Given this list of marker genes PITRM1, CSRP2, APOBEC3B, MICB, KRT20 (keratin 20), SEC61A2, SOCS7, MPZL1, OPTN, MAFB, SH2B3, CAVIN1, F11R (NCBI Gene Id 50848), FHL1, PMEPA1, REPS2, SERPINI1, KDELR3, CLGN, JUN, LIFR, IFFO1, PLAC1, NRGN, SSX3, ZNF571, JPT1, TIMP2, MAGEB2, MKLN1, CDKN1A, AAMDC, PIK3CD, CTSV, ZMIZ2, ATP6V1D, MAP1LC3B, SYNJ2, CDKN2D, ZNF79, TMEM158, FLNC, OXTR, SPTLC2, SLC6A8, STAT3, ODC1, MAP2K3, HSPA2, ENO2, ATF3 (activating transcription factor 3), PLK3, CDR2L, GLS (NCBI Gene Id 51679), DUSP14, TRIO, ZNF331, H2BC8, TSC22D2, ITCH, C3orf52, FERMT2, KCNV2, TUBB2A, ATP6V0D1, SPANXA1, TNNC2, ALPP, MAP3K14, HSD17B1, ZNF222, MICA, SLC12A6, RAPGEF2, CLTB, TAF7L, MAGEB1, PARP12, NMT2, PKP2, AFF4, CTAG1B, TDRD12, MAGEA9, RPA4, ARF4 (NCBI Gene Id 378), COL1A2, IGF2, CLIC3, LSR, AK1, FUCA1, H2BC5, SSX4, MOK, CYLD, GCH1, PGF, DNMBP (dynamin binding protein), PAGE1, SBNO1, TUBA3C, HYAL1, PLIN3, AKAP17A, KRT12, CT55, YKT6, ITPR1, IRF7, MAP4K1, NHERF1, NPTX1, SSX2, NNAT, CYP26A1, PISD, NEU1, BMPR2 (NCBI Gene Id 659), TYRO3, VCX, RBM34, LAT2, ASB6, UPP1, SYT11, TEF (NCBI Gene Id 85370), APOLD1, STX3, TKTL1 (NCBI Gene Id 8277), IFI30, SPHK1, CARD14, FKBP1B, TTLL7, NXT2, HCLS1, SLC7A6, MLEC, APBB2, ATP6V0A1, INPP5F, IL23A, NOP14-AS1, HABP4, PRKAB2, TUBB2B, SPAG9, ENSG00000310059, MOSPD1 (NCBI Gene Id 56180, motile sperm domain containing 1), DGKZ, EHD4, RGPD5, CLMN (NCBI Gene Id 79789), RASGRP2, CGREF1, RGS9, ILRUN, KLF12, GAB2, DPEP3, MMP2, HSD17B6, BAIAP3, CD9, SSX1, AKAP12, DAZL, HDAC5, TIMP1, H2AC10P, SMPD3, DNAJB2, H1-2, SKIL, GDF11, GOSR2, STK10, ORMDL2, ABHD2, MAGEC1 (MAGE family member C1), SENP5, H2AC11, CDO1, ECM1, NRIP3, EHD1, LUZP4, here is a description of the gene set: Genes up-regulated in 3 out of 4 NSCLC cell lines (non-small cell lung cancer) after treatment with azacitidine and TSA. Human Gene Set: ZHONG_RESPONSE_TO_AZACITIDINE_AND_TSA_UP from publication Zhong S, Fields CR, Su N, Pan YX, Robertson KD (PMID 17043644) studied in species Homo sapiens Lung cancer is the leading cause of cancer-related deaths in the United States due, in large part, to the lack of early detection methods. Lung cancer arises from a complex series of genetic and epigenetic changes leading to uncontrolled cell growth and metastasis. Unlike genetic changes, epigenetic changes, such as DNA methylation and histone acetylation, are reversible with currently available pharmaceuticals and are early events in lung tumorigenesis detectable by non-invasive methods. In order to better understand how epigenetic changes contribute to lung cancer, and to identify new disease biomarkers, we combined pharmacologic inhibition of DNA methylation and histone deacetylation in non-small cell lung cancer (NSCLC) cell lines, with genome-wide expression profiling. Of the more than genes upregulated by these treatments, three of these, neuronatin, metallothionein 3 and cystatin E/M, were frequently hypermethylated and transcriptionally downregulated in NSCLC cell lines and tumors. Interestingly, four other genes, cylindromatosis, CD9, activating transcription factor 3 and oxytocin receptor, were dominantly regulated by histone deacetylation and were also frequently downregulated in lung tumors. The majority of these genes also suppressed NSCLC growth in culture when ectopically expressed. This study therefore reveals new putative NSCLC growth regulatory genes and epigenetic disease biomarkers that may enhance early detection strategies and serve as therapeutic targets.